The following is a description of a gene set: from publication Chen Y, Wang X (PMID 31504780) studied in species Mus musculus Mouse Gene Set: MIR_200C_3P Genes predicted to be targets of miRBase v22 microRNA mmu_miR_200c_3p in miRDB v6.0 with MirTarget v4 prediction scores > 80 (high confidence targets)., and this is the list of marker genes: Wapl, Evi5, Eps8, Sox5, Scd1, Cfl2, Mtfr1, Cecr2, Fli1, Xkr4, Phtf2, Gtf2e1, Phf11d, Nab1, Efnb2, Gabpa (NCBI Gene Id 14390), Ptpn12, Gpr161, Il10, Rims2, Sema3f, Mtmr6, Six1, Uqcc5, Rbsn, Hspa13, Pgm2l1, Zfp185, Sox2, Eif4e2, Arhgap20, Clic4, Hmgb3, Fignl2, Suz12, Ranbp9 (NCBI Gene Id 56705), Trim33, Ngef, Zfp711, Hdhd2, Slc6a1, Tln1, Gtf3c4, Foxg1, Gli3, Ankrd44, Bnc2, Nup107, Usp27x, Dpy19l1, Gpm6a, Shprh, Csnk1g3, Phf11b, Nek9, Erg, Reck, Slk, Smim13, Dnajb5, Syvn1, Hapstr1, Fut9, Cnot7, Hook3, Ago2, Bnip3l, Obox5, Nanos1, Ube2w, Synj1, Nr3c1, Cilk1, Eloc, Jun, Elmod2, Zfta, Commd3, Dennd1b, Pi4kb, Tfap2a, Frmd6, Atxn1, Fbxw7 (F-box and WD-40 domain protein 7), Clasp2, Nufip2, Nbr1, Ets1, Pcdh19, Immp2l, Npc1, Phc3, Serinc1, Qki, Fhl4, Vat1l (vesicle amine transport protein 1 like), Dlc1 (NCBI Gene Id 50768), Ppp4r1, Rtf1, Prr11, Slc38a2, Foxf1, Zeb2, Tln2, Tmem200c, Ppm1b, Clip1, Egln1, Foxp1, Nectin4, Mtss2, Ptpn21, Tbx5, Osbpl11, Msn, Xkr8, Pld5, Cops8, Ipo8, Nova2, Dach1, Pkia, Arid4b, Rasa2, Ppp1r3g, Syde1, Jazf1, Gpatch8, Ensa, Myo9a, Adamts6, Ttc14, Syncrip, Atl2, Ppp1r9b, Pik3cb, Yipf5, Lats2, Oxr1 (oxidation resistance 1), Osgepl1, Col4a3, Khdrbs1, Scn5a, Phf11a, Mmp12, Hipk3, Bag5, Plpp3, Clasp1, Vash1, Lrp1, Arl5b, Mboat2, Hs3st1, Mmgt1, Lhfpl6, Fbxw11, AI593442 (expressed sequence AI593442), Ppm1f, Bap1 (NCBI Gene Id 69465), Trmt9b, Paxip1, Ptpn14, Mospd2, Zfp68, Ano5, Mtf2, Unc5d, Ric1, Piga, Thap1, Nrbp1, Ypel2, Ssr3, Atp11c, Rab21, Uba6, Cd302, St6galnac5, Phf21b, Tob1, Plcl1, Casp2, Syne1, Rbfox2, Wasf1, Srsf1 (NCBI Gene Id 70724, serine and arginine-rich splicing factor 1), Ddx3y, Fez2, Slc14a1, Zeb1, Ywhag (tyrosine 3-monooxygenase/tryptophan 5-monooxygenase activation protein, gamma polypeptide), Sptssa, Stap1, Ckap4, Dennd5b, Prkg1, Rnf169, Sec24a, Rusc2, Aldh1a7, Poglut3, Gnai3 (NCBI Gene Id 99910), Npy2r, Chrdl1, Tent4b, Polr1f, Ice2, Igsf3, Rps6kb1 (ribosomal protein S6 kinase, polypeptide 1), Sema6d, Crtap, Zfp217, Igsf10, Wipf1, Asf1a, Pkd1, Slc30a4, Fndc3b, Lce1c, Strap, Zfpm2, Sh3gl1, Ccnj, Marchf8, Mgat2, Foxn2, Mosmo, Myof, Phf6, Ncs1 (neuronal calcium sensor 1), Hnrnpd, Lamc1, Myb, Gpr75, Tsc22d2, Capn6, Acaca, Slitrk1, Adipor2, Ugt8a, Tex2, Xkr6, Rgl1, Fam118b, Eif5b, Sfxn1, Mgp, Rab11fip2, Rap1b, Cdh20, Pfpl, Coro1c, Ywhab, Nr5a2, Psip1, Crkl, Ntf3, Slc35a2, Elmod1, Lrp1b, Asap1 (ArfGAP with SH3 domain, ankyrin repeat and PH domain1), Agfg1 (NCBI Gene Id 98611), Cnot6, Phf11c, Phactr3, Cbx3, Nfia, Nova1, Dnajb6, Dek, Sgk3, Gpr158, Slc1a2, Arih1, Depdc1b (DEP domain containing 1B), Esrrg, Nck2, Spryd7, Mindy2 (NCBI Gene Id 235461), Csmd3, Ncoa7, Paip1, Ppp1r18, Hipk1, Cntn1, Rdh10, Cep350, Ankrd40, Pcmtd1, Matr3, Tbk1, Golga1, Itsn2, Ap1s2, Nedd1, Hpse, Ulk2, Hmbox1, Tbc1d12, Golga7, Slit2, Sec23a, Pof1b, Pds5b, Aff3, Gata4, Pdik1l, Sfr1, Cdk17, Tjp1, Pom121l12 (POM121 membrane glycoprotein-like 12), Map3k1, Cert1, Zic3, Dennd5a, Med13, Zfp131, Fhl1 (NCBI Gene Id 14199), Nrf1, Sulf1, Ints8, Rapgef2, Zfp871, Vash2, Rnd3, Arhgap6, Slc10a4, Cnep1r1, Spag9, Wdr82, Lrrk2, Desi2, Rap2c, Ccnyl1, Map2, Ube3a, Sesn1, Oat, Errfi1, Amfr, Zfand6, Trappc14, Anln, Tram1l1, Mmd, Cntn4, Slc23a2, Taok1, Adamts8, Tubb5 (tubulin, beta 5 class I), Scrt2, Sik1, Pik3ca, Mprip, Ankrd45, Fbxo33, Tsc22d1, Zcchc24 (NCBI Gene Id 71918)